Given this list of marker genes LRRC8E, ANO3, BEST3, SGK3, SLC5A8, GABRA4, PANX1, BSND, CLIC2 (chloride intracellular channel 2), TMC4, NMUR2, ANO2, GABRB1, GABRP, CLCNKA, CLIC3, CLDN17, CLCN2 (NCBI Gene Id 79179), SLC26A9, SLC17A7, DCD, GABRA3, CLCN5, GABRG3, MFSD8, P2RX5, TTYH1, CLDN4, LRRC8A, APOL1, CLCN1, PACC1, GABRD, ANO9, NHERF1, SLC17A8, VDAC3, GABRA1, TTYH3, BEST4, BEST1, GABRB2, STX8, GABRQ, CLCC1, GLRB, GABRG1, CLCN4, CLIC6, SLC17A6, OCA2, CLCNKB, CFTR, CLCA1, GABRR3, CHRNA7, LRRC8D, STX1A, GLRA3, SLC17A3, GABRG2, CLCN7, GPR89A, C8orf44-SGK3, ANO1, TTYH2, ANO6, CLCA4, VDAC2, CLIC4, SLC1A7, CLCN3, LRRC8C, SLC26A7, GABRR1, GLRA2, SLC26A6, ANO8, GABRA6, VAMP8, FXYD3, VTI1B, LRRC8B, GABRE, MCOLN1, SHOC2, GABRR2, GABRB3, ANO4, STX7, CLIC5, CLIC1, ANO5, CLCN6 (chloride voltage-gated channel 6), SLC1A4, AQP6, SLC26A8, SLC26A11, ANO10 (NCBI Gene Id 55129), GPR89B, SLC1A1, VDAC1, ANO7, MCOLN3, SGK1, CCT8L2, CLCA2, GABRA2, GABRA5, BEST2, FXYD1, GLRA1, here is a description of the gene set: Enables the energy-independent facilitated diffusion of a monoatomic anion through a transmembrane aqueous pore or channel. species: Homo sapiens Human Gene Set: GOMF_MONOATOMIC_ANION_CHANNEL_ACTIVITY